Given this list of marker genes KHDRBS3, ELOVL2, PDCD4, QKI, RBP1 (retinol binding protein 1), SPTSSA, EMP1, PTPRK, GATA3, IGF1R, CCND1, TIAM1, PKIA, ZNF43, OSBPL1A, LIPF, PEG10, TCN1, ME1 (malic enzyme 1), ESRRG, FGFR1, GJA1, NR2F2, BCAS2, NFIB, TTK, CLCA2, MSX2, LBR (NCBI Gene Id 653311), IL1R1, CXCL8, MBOAT7, PDZK1, HDAC2, DUSP6 (dual specificity phosphatase 6), ORC3, TRIM16, LRP2, TRGC1 (NCBI Gene Id 6966), ADAM17, SEMA3C, ACAA2, CD24, CRYBG1, AREG, IRF3, CEP170, MSX1, COX7A2, ALDH3B2, TSPAN6, IGFBP5, TM4SF1, AGPS, here is a description of the gene set: studied in species Homo sapiens Genes down-regulated in a breast cancer cell line resistant to tamoxifen compared to the parental line sensitive to the drug. Human Gene Set: BECKER_TAMOXIFEN_RESISTANCE_DN The reasons why human mammary tumors become resistant to tamoxifen therapy are mainly unknown. Changes in gene expression may occur as cells acquire resistance to antiestrogens. We therefore undertook a comparative gene expression analysis of tamoxifen-sensitive and tamoxifen-resistant human breast cancer in vivo models using Affymetrix oligonucleotide arrays to analyze differential gene expression. Total RNAs from the tamoxifen-sensitive patient-derived mammary carcinoma xenograft MaCa 3366 and the tamoxifen-resistant model MaCa 3366/TAM were hybridized to Affymetrix HuGeneFL and to Hu95Av2 arrays. Pairwise comparisons and clustering algorithms were applied to identify differentially expressed genes and patterns of gene expression. As revealed by cluster analysis, the tamoxifen-sensitive and the tamoxifen-resistant breast carcinomas differed regarding their gene expression pattern. More than 100 transcripts are changed in abundance in MaCa 3366/TAM as compared with MaCa 3366. Among the genes that are differentially expressed in the tamoxifen-resistant tumors, there are several IFN-inducible and estrogen-responsive genes, and genes known to be involved in breast carcinogenesis. The genes neuronatin (NNAT) and bone marrow stem cell antigen 2 (BST2) were sharply up-regulated in MaCa 3366/TAM. The differential expression of four genes (NNAT, BST2, IGFBP5, and BCAS1) was confirmed by Taqman PCR. Our results provide the starting point for deriving markers for tamoxifen resistance by differential gene expression profiling in a human breast cancer model of acquired tamoxifen resistance. Finally, genes whose expression profiles are distinctly changed between the two xenograft lines will be further evaluated as potential targets for diagnostic or therapeutic approaches of tamoxifen-resistant breast cancer. from publication Becker M, Sommer A, Krätzschmar JR, Seidel H, Pohlenz HD, Fichtner I (PMID 15657362)